Given this list of marker genes Ccl2, Aco2, Tnf, Sod2, Th, here is a description of the gene set: Any process that results in a change in state or activity of a cell or an organism (in terms of movement, secretion, enzyme production, gene expression, etc.) as a result of a lack of contact with other members of the same species. Mouse Gene Set: GOBP_RESPONSE_TO_ISOLATION_STRESS species: Mus musculus